Given this list of marker genes SLC8A1, GIPC3, MAP3K9 (mitogen-activated protein kinase kinase kinase 9), GYPC, TTLL12, ZNF704, STC2, EPHB1, MBNL3, CFL2, PA2G4, PSMA5, UBN2, FLT1, GRSF1, FBXO16 (NCBI Gene Id 157574), ARL8A, SLC6A8, SLC22A2, SDHB (NCBI Gene Id 96200), TMEM43, URGCP, ROCK2, KRTAP5-10, NDST1, LIMD1, FBXL17, CBX6, INMT, HIPK2, BNC2, BCL2L14 (NCBI Gene Id 79370), LCE1A, EOLA1, ADAM33, FMOD, BOLL, OPN4, HECA, CACNG2, RCAN2, CUL3, TMEM198, PHF2, RAP1GAP2, SLC13A5, EEPD1, TNNI1, SLC7A1 (solute carrier family 7 member 1), NSD1, POLR2J2, FMNL3, PTPN14, HYCC2, ZKSCAN3, NIPAL4, ITGA5, SORT1, ZZZ3, NBEAL2, RASSF4, MC5R (NCBI Gene Id 4161), PHF21A, ATP4A, MUC13, BORA, RUNX3, URM1, GALNT15, SUFU, GPATCH8, NAP1L5, CYP21A2, ZNHIT3, USH1G, MTCL2, RAB11FIP4, MLLT6 (NCBI Gene Id 4302), ZBTB18, EIF4EBP2, here is a description of the gene set: Human Gene Set: MIR4487 Genes predicted to be targets of miRBase v22 microRNA hsa-miR-4487 in miRDB v6.0 with MirTarget v4 prediction scores > 80 (high confidence targets). species: Homo sapiens from publication Chen Y, Wang X (PMID 31504780)